The following is a description of a gene set: species: Mus musculus Enables the energy-independent facilitated diffusion of water through a transmembrane aqueous pore or channel. Mouse Gene Set: GOMF_WATER_CHANNEL_ACTIVITY, and this is the list of marker genes: Aqp7, Aqp9, Pdpn, Aqp5, Aqp4, Aqp3, Mip (major intrinsic protein of lens fiber), Aqp1, Aqp6 (NCBI Gene Id 239663), Aqp11, Aqp8, Aqp2